The following is a description of a gene set: Reactome Pathway: Developmental Lineage of Mammary Gland Alveolar Cells studied in species Homo sapiens Mammary gland luminal progenitor cells commit to either a ductal fate, producing ductal epithelial cells that line the mammary gland ducts, or to an alveolar fate, producing milk-secreting alveolar cells. NOTCH signaling, WNT signaling, and hormone receptor signaling play deciding roles in fate determination of luminal progenitors, with hormone receptor negative luminal progenitors committing to the alveolar fate and hormone receptor positive luminal progenitors committing to the ductal epithelial fate. Hormone receptor negative luminal progenitors produce alveolar progenitors, which are likely to be hormone receptor negative. The commitment of luminal progenitors to alveolar fate is induced during pregnancy. In mice, inactivation of Notch signaling in luminal progenitor cells drives their commitment to alveolar cell identity. Downregulation of Notch signaling in hormone receptor-negative luminal progenitors may be due to FERMT2 (also known as Kindlin-2)-mediated downregulation of Stat3-mediated expression of Notch ligand Dll1 in myoepithelial cells. After cessation of lactation, alveolar cells in the mammary gland die during the involution process, however, mouse lineage tracing studies suggest that some alveolar progenitors/precursors survive the involution and function as self-renewing alveolar precursors in subsequent pregnancies. part of: Developmental Lineages of the Mammary Gland, and this is the list of marker genes: PRL